Given this list of marker genes COL2A1, SLF2, RPS6KA3, AMN, FGFR3, GALNS, VPS33A, ATG7, POLR3GL, here is a description of the gene set: studied in species Homo sapiens Lumbar kyphosis Human Gene Set: HP_LUMBAR_KYPHOSIS Over curvature of the lumbar region.